Given this list of marker genes NMU, ABAT, TNFRSF11A, TNFSF11, TNF, APLN, HTR2A, SLC27A1, PTGS2, PTGER3, IL1B, here is a description of the gene set: Any process that activates or increases the rate or extent of heat generation. Human Gene Set: GOBP_POSITIVE_REGULATION_OF_HEAT_GENERATION species: Homo sapiens